Given this list of marker genes SLC38A2-AS1, RPL21, FST, ZNF773, SNORD12B, MIR7111, HNRNPH1, RABGGTB, SNORD49A, SNORA81, RPL3, RPL34, SNORD12, HNRNPK, SGK1, SNRPG, GAS5, NTS, EIF4A2, RPL12, SRSF1, MRPS30, SFPQ, RBM39, SLC38A2, SNORA63, VPS52, PNRC2, H3C4, SNORA63B, EEF1A1, SNORD45A, RPL17, here is a description of the gene set: Genes containing one or more binding sites for (PER1) in their promoter regions (TSS -1000,+100 bp) as identified by GTRD version 20.06 ChIP-seq harmonization. from publication Yevshin I, Sharipov R, Kolmykov S, Kondrakhin Y, Kolpakov F (PMID 30445619) Human Gene Set: PER1_TARGET_GENES species: Homo sapiens